Given this list of marker genes Sgtb, Bag6, Folr2, Glp1r, Sec61a1, Get4, Sec61a2, Sec61b, Ubl4a, Sec62 (SEC62 homolog, preprotein translocation), Macf1, Hspa5, Get1, Get3, Folr1, Sec61g, Sgta, Chmp4b, Sec63, here is a description of the gene set: The targeting of proteins to a membrane that occurs after their translation. Some secretory proteins exhibit posttranslational transport into the endoplasmic reticulum (ER) lumen: they are synthesized in their entirety on free cytosolic ribosomes and then released into the cytosol, where they are bound by chaperones which keep them in an unfolded state, and subsequently are translocated across the ER membrane. Mouse Gene Set: GOBP_POST_TRANSLATIONAL_PROTEIN_TARGETING_TO_ENDOPLASMIC_RETICULUM_MEMBRANE studied in species Mus musculus